The following is a description of a gene set: species: Mus musculus Mouse Gene Set: GOBP_NEGATIVE_REGULATION_OF_SISTER_CHROMATID_COHESION Any process that stops, prevents, or reduces the frequency, rate or extent of sister chromatid cohesion., and this is the list of marker genes: Recql4, Naa10, Wapl, Atrx, Tnks